The following is a description of a gene set: In the present study we used Affymetrix oligonucleotide microarrays to produce gene transcription profiles for the major leukocyte types in humans. This comprehensive dataset enabled us to not only establish which genes were expressed in each leukocyte type, but also which genes were expressed in each subset after activation. The used of a comprehensive dataset of gene profiles from all the major human leukocyte subsets enabled a novel and powerful means for identification of genes associated with single leukocyte subsets, or different immune paradigms. studied in species Homo sapiens Human Gene Set: GSE3982_MEMORY_CD4_TCELL_VS_TH1_DN from publication Jeffrey KL, Brummer T, Rolph MS, Liu SM, Callejas NA, Grumont RJ, Gillieron C, Mackay F, Grey S, Camps M, Rommel C, Gerondakis SD, Mackay CR (PMID 16474395) Genes down-regulated in comparison of memory CD4 T cells versus Th1 cells., and this is the list of marker genes: LAG3, NUTF2, FES, AK2, VDAC1, OIP5, CDC6, MTHFD2, DUSP4, NCAPG2 (NCBI Gene Id 54892), PHLDA1, PDK3, IER3, PDSS1, SLC1A5, SCN3A, LDLR, EMP1, PPIF, PA2G4 (NCBI Gene Id 5036), RECQL4, DUSP6, CFLAR, COQ2, VDAC2, DNAJA1, ALG8, SNRNP25, RAB11FIP1, GPI, RNASEH2A, PAF1, GMNN, KIF20B, GRB2, MRPL12, CALML4, GGT1, SLC7A5, KIN, RRM1, MYH6, FAH, TTK, WARS1, APOBEC3B, DLAT, BUB1, PSMD14, RALA, TIMP2, GNL2, MAD2L1, YBX3, IFI6, TCTN3, AP2B1, MCM2, CSE1L, PSMB5, EMC8, ACOT7, SLC25A46, NDC80, CALU, NDUFAF3, CDK1, HSP90AB1 (heat shock protein 90 alpha family class B member 1), ARL3, ORC6, IDH3A, PSMA3, MCM6, RDX, TPI1, SDC4, MARCHF5, PPCDC, SUPT4H1, NUP37 (NCBI Gene Id 79023), NFE2L3, CEBPG, APOD, MRPL13, XRCC6, RHOB, SLA, VDR, SQLE (NCBI Gene Id 6713), NDUFV2, FILIP1L, MCUR1, CKS2, RAD51C, CSF2, DTL, EMC2, GSTT1, ASIC3, CENPU, TIPIN, RRM2, MSH2, PDE4D, ALDH3A2, ZDHHC14 (NCBI Gene Id 79683), AHCY, PSMD6, PRMT5, MYH10, ENO1, ERCC1, SERPINB1, GGH, PSMB6, CSNK2A1, PCDH12, LAP3, STK3, NASP, RTCB, QPRT, CDK7, PSEN2, PLAUR, ATP6V0B, CEMIP2, NHP2, ATP2A2, SLC25A32, ANXA3, IRF4, VCP (NCBI Gene Id 94731), PERP, IFNG, NAMPT, CDCA8, RCAN1, HK3, SPRY1, TUBB3, P2RX5, GINS1, JPT2, GINS2 (NCBI Gene Id 51659), POLE2, COL1A2, ENY2, GARS1, GGCT, PYCR1, ACOX1, SMC2, TMEM70 (transmembrane protein 70), PSMD12, KIF11, HELLS, GTF2A2, MTHFD1 (methylenetetrahydrofolate dehydrogenase, cyclohydrolase and formyltetrahydrofolate synthetase 1), PMAIP1, FLOT1, H2AX, HSPE1, UBE2K, LRRC59, AKR1B1, STIP1 (NCBI Gene Id 10963), VRK1, CCT2, CD200, ORMDL2, GPN3, EOLA2, CSNK2B, ATP9A (ATPase phospholipid transporting 9A (putative)), SCO2, BUD23, PSMD11, MCM5, FN1, COMT, BLM, TOR3A, CCDC85B, MFAP1, CKS1B, BCL3, RCC1, SPOCK1, SLC16A3, SCD, STEAP1, PSMB2, TIMELESS, PSMB10, NCAPH (non-SMC condensin I complex subunit H), PBK, BLTP3B, P4HA1